Given this list of marker genes Vasp, Cish, Nfkb1, Cltc, Arhgap31, Ngfr, Vrk1, Kif1a, Bbip1, Efhd2, Cdk2ap2, Rufy3, Cflar, Trio (NCBI Gene Id 77730), Cd83 (NCBI Gene Id 12522), Ahr, Cd209e, Gfra2, Orai1, Serpina3g, Cyp4f16 (NCBI Gene Id 70101), Reep3 (NCBI Gene Id 28193), Iqgap1, Clic4, Irf5, Slc3a2, Naaa, Dok2, Nrp2, Tarm1, Snx8, Napsa, Frmd4b (FERM domain containing 4B), Kmo, Pdcd1lg2, Prkcd, Nr4a3, Cacnb2, Syngr2, Rara, Malt1, Adam8, Cd40, Sdc4, Tnip3, Fabp5, Wdr33, Clec4n, Ctsz, Ccl17, Icam1, Mvp, Jak2, Ptpn1, Slc15a3, Lrrk1, Ppp1r18 (protein phosphatase 1, regulatory subunit 18), Slc30a4, Selenos, Rab3il1, Gpbp1, Irf4, Eps8, Etv3, Ly9, Plek, Rab14, Cdkn1a, here is a description of the gene set: Mouse Gene Set: CUI_CDC2_TSLP_RESPONSE_UP Genes positively differentially expressed in cell type: cDC2 (conventional dendritic cell type 2) upon treatment with cytokine: TSLP in mouse lymph nodes in vivo. Cytokines mediate cell-cell communication in the immune system and represent important therapeutic targets. A myriad of studies have highlighted their central role in immune function, yet we lack a global view of the cellular responses of each immune cell type to each cytokine. To address this gap, the authors created the Immune Dictionary, a compendium of single-cell transcriptomic profiles of more than 17 immune cell types in response to each of 86 cytokines (>1,400 cytokine-cell type combinations) in mouse lymph nodes in vivo. A cytokine-centric view of the dictionary revealed that most cytokines induce highly cell-type-specific responses. For example, the inflammatory cytokine interleukin-1β induces distinct gene programmes in almost every cell type. A cell-type-centric view of the dictionary identified more than 66 cytokine-driven cellular polarization states across immune cell types, including previously uncharacterized states such as an interleukin-18-induced polyfunctional natural killer cell state. from publication Cui A, Huang T, Li S, Ma A, Pérez JL, Sander C, Keskin DB, Wu CJ, Fraenkel E, Hacohen N (PMID 38057668) studied in species Mus musculus